The following is a description of a gene set: Any process that activates or increases the frequency, rate or extent of protein monoubiquitination. Human Gene Set: GOBP_POSITIVE_REGULATION_OF_PROTEIN_MONOUBIQUITINATION species: Homo sapiens, and this is the list of marker genes: UBB, PEF1, PDCD6, FANCM, BIRC2